Given this list of marker genes TP53, BMF, APAF1, YWHAQ, NMT1, AKT2, TP53BP2, CDKN2A, YWHAE, PMAIP1, PPP3CC, YWHAB, UACA, DIABLO, TFDP2, PPP1R13B, CARD8, PPP3R1, YWHAZ, GZMB, GSDME, E2F1, XIAP, CYCS, BID, MAPK8, BBC3, GSDMD, BCL2, CASP8, TFDP1 (transcription factor Dp-1), CASP9, TP73, STAT3, YWHAH, DYNLL1, BCL2L1, MAPK3, BAX (BCL2 associated X, apoptosis regulator), C1QBP, BAK1, AVEN, APIP, SEPTIN4, SFN, BCL2L11, MAPK1, CASP3, BAD, AKT3, DYNLL2, AKT1, TP63, CASP7, YWHAG, here is a description of the gene set: part of: Apoptosis Reactome Pathway: Intrinsic Pathway for Apoptosis The intrinsic (Bcl-2 inhibitable or mitochondrial) pathway of apoptosis functions in response to various types of intracellular stress including growth factor withdrawal, DNA damage, unfolding stresses in the endoplasmic reticulum and death receptor stimulation. Following the reception of stress signals, proapoptotic BCL-2 family proteins are activated and subsequently interact with and inactivate antiapoptotic BCL-2 proteins. This interaction leads to the destabilization of the mitochondrial membrane and release of apoptotic factors. These factors induce the caspase proteolytic cascade, chromatin condensation, and DNA fragmentation, ultimately leading to cell death. The key players in the Intrinsic pathway are the Bcl-2 family of proteins that are critical death regulators residing immediately upstream of mitochondria. The Bcl-2 family consists of both anti- and proapoptotic members that possess conserved alpha-helices with sequence conservation clustered in BCL-2 Homology (BH) domains. Proapoptotic members are organized as follows: <p> 1. "Multidomain" BAX family proteins such as BAX, BAK etc. that display sequence conservation in their BH1-3 regions. These proteins act downstream in mitochondrial disruption. <p> 2. "BH3-only" proteins such as BID,BAD, NOXA, PUMA,BIM, and BMF have only the short BH3 motif. These act upstream in the pathway, detecting developmental death cues or intracellular damage. Anti-apoptotic members like Bcl-2, Bcl-XL and their relatives exhibit homology in all segments BH1-4. One of the critical functions of BCL-2/BCL-XL proteins is to maintain the integrity of the mitochondrial outer membrane. studied in species Homo sapiens